Given this list of marker genes GPD1, PPARG, SLC2A1, LDHA, TPI1, CD36, HIF1A, GPAT3, GAPDH, here is a description of the gene set: Human Gene Set: WP_HIF1A_AND_PPARG_IN_HYPERTROPHIC_CARDIOMYOPATHY studied in species Homo sapiens HIF1A and PPARG in hypertrophic cardiomyopathy